Given this list of marker genes PGM1, UQCRC1, ITGB5, ACOT7, DCAF8 (NCBI Gene Id 50717), FOXO3, CD2AP, DDX39A, YWHAH, PITPNM1, SARS1, INPP5D, SMARCD2, ARHGEF18 (Rho/Rac guanine nucleotide exchange factor 18), DDAH2, EIF3H, TRIO, MCM6, TARDBP, MACROH2A1, SIVA1, AHCY, ATPAF2, NCF4, PFKL, UPF3A, ASTN1, SSRP1, ADORA3, DAB2, RPP38, GIT2, MDH1, IER2, LYL1, ATXN2, ADAM15, SEPTIN9, IDH3A, CHN2, UBN1, ESRRA, ISG20L2, DNPEP, SIPA1L3, SPHK2, BAAT, TUSC2, SLC38A10 (solute carrier family 38 member 10), STARD3, ASXL1, MFN2, PTGS1 (prostaglandin-endoperoxide synthase 1), CALB2, RBL2, SDC3, SPTAN1, PTP4A2, CYFIP1, FOLH1, RNF167 (NCBI Gene Id 26001), SYT17, RGS14, ADNP, SLC25A11, SH3BGR (NCBI Gene Id 8211), DOCK3, USF2, TP53, MCM3AP, CD9, KRT16, ZNF266, GAS7, XPOT, ATP5MC3, ANP32A, TAB1, INPP1, LDHB, CDC5L, CCT4, NHP2, TIMP2, CCNH, SMARCE1, PLCB2 (NCBI Gene Id 5330), P2RY11, TLE4, WDR7, LTA4H, FOXN3, RETREG3, TNFRSF10B, MEGF9, SNAPC2, SNU13 (small nuclear ribonucleoprotein 13), COX7C, SP3 (NCBI Gene Id 6670), ZMYM2, ACY1, CAMTA2, HSF1 (NCBI Gene Id 642255), ZDHHC3, GGA2, PRMT1 (protein arginine methyltransferase 1), H2AZ2, CEBPG, ALDH1A1, VPS52, POM121, STAT6, CAMK1, HEXB, MKNK1, ICAM3, CD33, SLC1A5, PEPD, NDUFS6, PECAM1, ERF, WDR43, SUGP2, PARP1, LAMB2, EIF3M, TMC6, ARHGAP4, GUCA1A, GGA3, BTF3, EEF1B2, JUND, THAP12, EVI2B, F13A1, CASP9, EIF2B4, ZNF384, LY86, MYO1F, RPL36A, LILRA2, NACA, PSEN2, FADD, PIP4K2A, SLC7A8, SDHA, PIK3CG, SAMM50, ATP8A1, SRSF6, ZNF217, APOC1, S100A4, RNH1, TBC1D22A, CPVL, RPS27A, RPL3, CDK10, UBA2 (NCBI Gene Id 10054), GTF3C2, PFKFB1, HDAC3, COMT, P2RY14, EIF4B, H2AZ1, MAN2A2, DDX42, GORASP2, LPXN, ABCC5, ITGA3, ATP11B, HOMER3 (NCBI Gene Id 9454), NARS1, ZFP36L2, DCTN2, HEBP2, ITPKB, MAPK9, SOCS1, HNRNPH1, CLEC10A, TOP2B, SGSM2, RNF187, RERE, SPARC, KXD1, SUN2, KAT2A, FAM131A, PYGL, KDELR1, NIPSNAP2, here is a description of the gene set: from publication Chaussabel D, Semnani RT, McDowell MA, Sacks D, Sher A, Nutman TB (PMID 12663451) species: Homo sapiens Genes up-regulated in comparison of dendritic cells (DC) versus DCs exposed to M.tuberculosis. Human Gene Set: GSE360_CTRL_VS_M_TUBERCULOSIS_DC_UP Monocyte-derived dendritic cells (DC) and macrophages (MΦ) generated in vitro from the same individual blood donors were exposed to five different pathogens, and gene expression profiles were assessed by microarray analysis. Responses to Mycobacterium tuberculosis and to phylogenetically distinct protozoan (Leishmania major, L. donovani, Toxoplasma gondii) and helminth (Brugia malayi) parasites were examined, each of which produces chronic infections in humans yet vary considerably in the nature of the immune responses they trigger.